Given this list of marker genes Igf1, Ddo, Asap1, Hesx1, Rasgrf2, Rev3l, Zfp354a, Ro60, Rnpc3, Tmem255a, Zfand6, Bcl7a, Utrn, Dennd1b, Nat3, Hnrnpa3, Rab3c, Itgb3bp, Bnc2, Ski, Brcc3, Rab5b, Tecrl, Sec31a, Gabpb1, Bcl2, Man1a, Atic, Kcnip3, Fzd1, Dop1a, Trak2, Sptssb, Mrps25, Sox6, Adam10 (NCBI Gene Id 67314), Actn1, Dennd10, Rps6kb1, Bicd1 (NCBI Gene Id 319962), Atp2b4 (NCBI Gene Id 381290), Camta1 (calmodulin binding transcription activator 1), Npat, Chgb, Zfp667, Arhgap6, Camk1d, Slc7a10, Lgals8, Hoxc10, Zmat2, Zfx, Flrt3, Agpat5, Ago3, Abhd5, Wac, Nrp1, Itga6, Arhgap36, Nbeal1, Dcun1d4, Gde1, Sec63, Gab1, Ppm1k, Col2a1, Stra6l, Snx5, Irf2bpl, Sgip1, Rarg, Pax9, Enpp6, B3galt1, Cd1d1, Ccdc12, Wipf3, Wdfy3, Endod1, Tnrc6a, Tmem47, Nup98, Caps2, Psmd12, Lin7a, Apc, Kctd3, Foxo3, Saxo1, Fndc5, Agfg1, Zfp715, Ankrd29, Arl5a, Nkain2 (Na+/K+ transporting ATPase interacting 2), Arid1a, Aak1, Cflar, Prnd, Snapc5, Foxc1 (NCBI Gene Id 17300), Clmp, Cacna2d1, Shank2, Bach2, Nwd2, Wwp1, Dennd2d, Nedd1, Rassf9, Gmfg, Dnajc27, Tnpo1, Pacsin2, Spock3, Ucp3, Tab3, Pabpc1l, Xpo7, Tanc1, Sel1l, Cggbp1, Ube2k, Cnot7, Sowahc (sosondowah ankyrin repeat domain family member C), Hmgn3, Ephb1, Tbx18, Gdi2, Jakmip3, Abcc3, Pja2, Adam19, Ccdc179, Ash1l, Purb, G3bp2, Fign, Foxd1, Ikzf2, Gpr149, Larp4b, Trappc8, Map6, Lrrn1, Chmp2b, Cdc42ep3, Sp8, 2310002L09Rik, Ninj2 (ninjurin 2), Foxp2, Dync1li1, Gspt1, Rassf5, Zfp882, Rab10, Eif4g2, Tigd4, Lzts3, Kctd1, Grik2, Oog4, Slc12a6, Chek1, Pax2, Hook3, Cdkn2b, Mob4, Cripto, Qki, Ets1, Tfrc, Ctdspl2, Atp2a2, Usp25, Coil, Gm527, Arfgef1, Rhov, Ntng1, Prrt2, Rock1, Lonrf1, Zfp677, Eif4g3 (NCBI Gene Id 76685), Sptbn4, Nup160, Med13l, Zbtb4, Slc17a6, Zfp36l1, Marcksl1, Dab2ip, Zfp281, Rbfox1, Prkaa2, here is a description of the gene set: from publication Chen Y, Wang X (PMID 31504780) Mouse Gene Set: MIR_450B_5P Genes predicted to be targets of miRBase v22 microRNA mmu_miR_450b_5p in miRDB v6.0 with MirTarget v4 prediction scores > 80 (high confidence targets). studied in species Mus musculus